Given this list of marker genes DDRGK1, TMBIM6, BFAR, DNAJB9, UFL1, HSPA5, here is a description of the gene set: Human Gene Set: GOBP_NEGATIVE_REGULATION_OF_IRE1_MEDIATED_UNFOLDED_PROTEIN_RESPONSE Any process that stops, prevents or reduces the frequency, rate or extent of the IRE1-mediated unfolded protein response. species: Homo sapiens